The following is a description of a gene set: Genes down-regulated in MEF cells (embryonic fibroblast) upon knockout of ATF2. Transcription factor ATF-2 is a nuclear target of stress-activated protein kinases, such as p38, which are activated by various extracellular stresses, including UV light. Here, we show that ATF-2 plays a critical role in hypoxia- and high-cell-density-induced apoptosis and the development of mammary tumors. Compared to wild-type cells, Atf-2(-/-) mouse embryonic fibroblasts (MEFs) were more resistant to hypoxia- and anisomycin-induced apoptosis but remained equally susceptible to other stresses, including UV. Atf-2(-/-) and Atf-2(+/-) MEFs could not express a group of genes, such as Gadd45alpha, whose overexpression can induce apoptosis, in response to hypoxia. Atf-2(-/-) MEFs also had a higher saturation density than wild-type cells and expressed lower levels of Maspin, the breast cancer tumor suppressor, which is also known to enhance cellular sensitivity to apoptotic stimuli. Atf-2(-/-) MEFs underwent a lower degree of apoptosis at high cell density than wild-type cells. Atf-2(+/-) mice were highly prone to mammary tumors that expressed reduced levels of Gadd45alpha and Maspin. The ATF-2 mRNA levels in human breast cancers were lower than those in normal breast tissue. Thus, ATF-2 acts as a tumor susceptibility gene of mammary tumors, at least partly, by activating a group of target genes, including Maspin and Gadd45alpha. species: Mus musculus from publication Maekawa T, Shinagawa T, Sano Y, Sakuma T, Nomura S, Nagasaki K, Miki Y, Saito-Ohara F, Inazawa J, Kohno T, Yokota J, Ishii S (PMID 17189429) Human Gene Set: MAEKAWA_ATF2_TARGETS, and this is the list of marker genes: CHL1, IGLL5, SULT2A1, ZG16B, CLCN1, MSTN (NCBI Gene Id 2660), CNR2, CCR3, ZIC2, PCNP, LRRN1, IGKV2D-30, SDF2, SLC1A5, FMO5, XRCC5, VPS13C, INA, KLK1, EIF2S3, CHIA (chitinase acidic), HTR4, DDX3Y, CRP, SIX4